Given this list of marker genes FANCD2, GOLGA8R, CDC42BPB, GOLGA8O, MTMR10, SMC5, MIR211, MITF (melanocyte inducing transcription factor), GOLGA8Q, APBA2, FANCI, STX1B, SMC6, STXBP1, LYPD6, EID3, RELA, DNMBP (NCBI Gene Id 23268), OTUD7A (NCBI Gene Id 161725), TRPM3, GJA1, GJC2, NSMCE3, APP, GOLGA8K, MYZAP, UBN1, CHRNA7, GJD3, GOLGA8J, TRPM1, CXADR, CANX, SERPINH1, HDAC1, CALM1, CCL5, ENTREP2, TJP3, GOLGA8H, KAT2B, NSMCE2 (NSE2 (MMS21) homolog, SMC5-SMC6 complex SUMO ligase), KLF13, NECAB3, SLF1, STX1A, GOLGA8T, RIC3, ANKRD2, FAN1, TJP1, TJP2, SLF2, OCLN, CREBBP, SIN3A, NSMCE1, SPEF1, CGN, here is a description of the gene set: Human Gene Set: WP_15Q11Q13_COPY_NUMBER_VARIATION 15q11q13 copy number variation species: Homo sapiens